The following is a description of a gene set: species: Homo sapiens Genes whose expression peaked at 60 min after stimulation of MCF10A cells with serum. Human Gene Set: AMIT_SERUM_RESPONSE_60_MCF10A from publication Amit I, Citri A, Shay T, Lu Y, Katz M, Zhang F, Tarcic G, Siwak D, Lahad J, Jacob-Hirsch J, Amariglio N, Vaisman N, Segal E, Rechavi G, Alon U, Mills GB, Domany E, Yarden Y (PMID 17322878) Signaling pathways invoke interplays between forward signaling and feedback to drive robust cellular response. In this study, we address the dynamics of growth factor signaling through profiling of protein phosphorylation and gene expression, demonstrating the presence of a kinetically defined cluster of delayed early genes that function to attenuate the early events of growth factor signaling. Using epidermal growth factor receptor signaling as the major model system and concentrating on regulation of transcription and mRNA stability, we demonstrate that a number of genes within the delayed early gene cluster function as feedback regulators of immediate early genes. Consistent with their role in negative regulation of cell signaling, genes within this cluster are downregulated in diverse tumor types, in correlation with clinical outcome. More generally, our study proposes a mechanistic description of the cellular response to growth factors by defining architectural motifs that underlie the function of signaling networks., and this is the list of marker genes: EGR3, PNRC1, CCN2, NR4A2, MAP3K8, PDLIM5, C1orf116, COBLL1, PXMP4, SGK1, POT1, TCEAL1, MBNL2, IER2, ITSN1, SOX4, BMP1, SERPINB13, TGIF1, NUAK2, CCN1, CCL20, ZC3H12A, PTGER4, FRMD4B, RCAN1, ETS2, PLK2, ELL2, HBEGF, TM4SF1, IRS2, TNC, TNFAIP3, MAFB, TRIB1 (NCBI Gene Id 80272), FN1, PMAIP1, SLC35D1, GAS1, CALD1, PTGS2, DUSP5, STK38L, PCBD1, TUFT1 (tuftelin 1), CYBRD1, SCD, VGLL3, EGR1, MAGED2, INHBA (inhibin subunit beta A), EREG, BHLHE40, CXCL8, KLF7, PIP5K1A, RHOB